The following is a description of a gene set: Ethanol metabolism resulting in production of ROS by CYP2E1 Mouse Gene Set: WP_ETHANOL_METABOLISM_RESULTING_IN_PRODUCTION_OF_ROS_BY_CYP2E1 species: Mus musculus, and this is the list of marker genes: Mafg, Cyp2e1, Sp1, Nfe2l2, Mafk, Maff, Map2k2, Map2k1, Prkcd, Mapk8